The following is a description of a gene set: In this study, an extensive analysis was conducted to define meta-programs (MPs) capturing intra-tumor heterogeneity across a spectrum of tumor types. The approach utilized non-negative matrix factorization (NMF) to analyze each cell type separately within individual tumor samples. This involved the analysis of malignant cells, macrophages, fibroblasts, endothelial cells, epithelial cells, T-cells, and B-cells. NMF was executed with varying parameter values (K=4, 5, 6, 7, 8, 9), thereby generating 39 programs for each cell type per sample. Each NMF program was summarized by the top genes based on NMF coefficients.\nRobust MPs were then delineated for each cell type using a set of stringent criteria, including recurrence within the same tumor, similarity to programs in other tumors, and non-redundancy within a tumor. Subsequently, these robust NMF programs were clustered (per cell type) based on Jaccard similarity, leading to the identification of MPs associated with each cell type.\nTo enhance the quality of the MPs, a refinement steps were undertaken, involving the removal of MPs suspected of reflecting low-quality data (with an overrepresentation of ribosomal proteins or mitochondrial-encoded genes), single-study inclusion, or similarity to miss-annotated cell types. studied in species Homo sapiens from publication Gavish A, Tyler M, Greenwald AC, Hoefflin R, Simkin D, Tschernichovsky R, Galili Darnell N, Somech E, Barbolin C, Antman T, Kovarsky D, Barrett T, Gonzalez Castro LN, Halder D, Chanoch-Myers R, Laffy J, Mints M, Wider A, Tal R, Spitzer A, Hara T, Raitses-Gurevich M, Stossel C, Golan T, Tirosh A, Suvà ML, Puram SV, Tirosh I (PMID 37258682) Human Gene Set: GAVISH_3CA_METAPROGRAM_EPITHELIAL_METABOLISM_KIDNEY_2 Genes upregulated in subsets of cells of a given type within various tumors, and this is the list of marker genes: SCNN1B, AQP3, PTGER1, MAN1A1, STC1, KRT19, MAL2, SCPEP1, ST6GAL1, TSPAN1, CLDN8, GATA3, TACSTD2, SMIM22, PTGR1, GATA3-AS1, SLC8A1, ASAH1, TPM4, HMGCS2, WNK1, IER3, CLDN7, NDRG1, PAPPA, EMX1, RTN3, ARG2, TMSB4X (NCBI Gene Id 7114), CDH16, LHX1, SELENOM, WFDC2, HSD11B2, CLU, CTSH, ATP1B1, RCAN1, FOLR1, FXYD4, CA2, EPCAM, BTG2, AQP2, RALBP1, ANXA2, SCNN1G, WSB1, CALB1, S100A2